The following is a description of a gene set: species: Mus musculus Mouse Gene Set: GOBP_COPII_COATED_VESICLE_CARGO_LOADING The formation of a macromolecular complex between the COPII coat proteins and proteins and/or lipoproteins that are going to be transported by the COPII vesicle to the Golgi., and this is the list of marker genes: Tbc1d20, Mia3, Scap, Sec31a, Sec24d, Sec31b, Insig1, Cideb, Sar1a, Surf4, Sec24a, Rab1a, Sec23b, Sec24c, Sec23a, Sar1b, Sec24b, Sec13